The following is a description of a gene set: Human Gene Set: ER_Q6_01 Genes having at least one occurrence of the motif KDMAYYNTGACCT in the regions spanning 4 kb centered on their transcription starting sites. This matches the ESR1 transcription factor binding site V$ER_Q6_01 (v7.4 TRANSFAC). species: Homo sapiens, and this is the list of marker genes: ZIC4, MAGED1, COX7A2L, SLC25A5, NNT, NDUFB3, BEST4, GLRA2 (glycine receptor alpha 2), GNRHR, TMEM71, PXN, UBE2K, NOG, RAP2C, PAK1IP1, TBR1, TPM3, CIAO2A, PNKD, HOXB7, TLX3, C1orf43, TMEM101, PTH1R, PRDM1, CAMKK2, PURA, POU3F3, SRP68, COPZ2, MT2A, ALDOA (NCBI Gene Id 226), SHF, MCC, UBE2R2, OTP, GNB1L, PHLDB1, PGF, DLG2, PRDM10, ITGB8, LINC00472, SHISA6, STMN1, NFIL3, NR4A2, CEP41, HS3ST2, PPM1E, IKZF2, MTMR11, NR1D1, CDK14, CSRNP3, EAPP, FGF6, TCF7, DCX, CXCL17, FAM210A, PPP4R3B, FSHB, SIK3, PKP4, GRID2, PSMF1, ZNF202, EVA1B, HOXB3, SATB1, RBMXL2 (RBMX like 2), NALF2, FBXW7, PPM1N, SLC25A1, GPR3, ATP6V0A4, TET2, NKX2-2, ERG, GCM1, ZNF532, GNAI1 (G protein subunit alpha i1), DNAJA2, RHOB, KCNN3, SERBP1, SKAP1, TNRC6C, ERN1, FKBP4, CNTN4, EIF2AK3, HYCC2, MIDEAS, ACO2, PDHA1, CDKL5, RRBP1, SLC6A9, CUTA, WNT11, RBBP9, DNMT3A, CALD1, WWC1, RBM24, GNA13, TREX2, CLDN12, HOXA3, GLI1, ELAPOR1, MAP1LC3A, BHLHE22, ASXL1, CHD2, SLC10A2, SLC9A1, SPATA7, SPTAN1, HIPK2, WBP1L, SLC4A7, ERBB4, ATP5F1A, WNT3, RNMT, ONECUT2, DGCR8, TLX2, RBMS1, AAMP, VTA1 (vesicle trafficking 1), ISL1, JOSD2, RTL10, GTPBP1, PDE6D, SPRED1, GAL3ST3, PDE1A, KIRREL3, BRMS1, RMDN2, NSUN5P2, SRPK2, OTX2, JARID2, FOXN3 (NCBI Gene Id 654111), DTNB, FGF13, IL1RAPL1, PCBP4, SCNN1A, TEX35, SYNJ2BP, MNT, MAP2K6, SDC1, C1orf21, MTMR10, EIF2B3, ZIC1, FBXL14, SYT16, GAS7, LRFN4, DBNDD2, CLUH, IRAG1, EIF4E, SPOCK2, NDRG2, UHRF2, LMNTD1, NYAP1 (NCBI Gene Id 222950), ZFP36L2, USP44, ZNF32, ACAP2, FCHSD2, CADM1, C12orf50, PPP1R16A, PLPPR1, PAM, ESRRB, S100A5, STARD6, LRRN3, B3GALT2, MTDH, PHF12 (NCBI Gene Id 57649), POLE3, RUNX1T1, ZFPM1, SAT1, B3GNT6, MID1, TAFA1, R3HDM2 (NCBI Gene Id 51220), TRPS1, SP6, TOMM40, CD37, MYH13, TBC1D21 (NCBI Gene Id 161514), NIPBL, NECAB3, BCL6, TBC1D15, PTCHD1, ATXN1, MITF, CREB5, SHH, HOXA10, CIC, INO80D, CALML6, LCP1 (NCBI Gene Id 3936), HOXB9, TBX6, LRRN1, GRM8, PHF5A, NDUFA4L2, LIFR, BNIP3L, FIGN, PPARA, PCDH8, HSPG2, VWA7, RIMS4, KMT2C, ATP5MC1, BRME1, IL23R, CD40LG, ZNF768 (NCBI Gene Id 79724), PDZK1, BTBD3, FGF9, ENOX2, IMMT, ESRP2, APEX2, TMTC1, SLC16A6, KIF6 (NCBI Gene Id 387085), CHRDL1, RAB11FIP1, CDC14A, EVA1C, CKB, GABARAPL2, DDR1, OVOL2, TINAG, EWSAT1, GFAP, SIRPA, SLC22A11, CDIN1 (CDAN1 interacting nuclease 1), CDKN2C, KDM2A, DLK2, LRP5, CBLN4, MROH7, MAP2K7, TSSK3, AOC2, GALNT15, RTN4, MICALL1, GREB1